The following is a description of a gene set: Thin nail Nail that appears thin when viewed on end. Human Gene Set: HP_THIN_NAIL studied in species Homo sapiens, and this is the list of marker genes: ALOXE3, RNU4-2, MBTPS2, TRPS1, IFT122, CAMK2B, HRAS, EZH2, EED, ANAPC1, SUZ12, RNU12, WNT10A, NSD1, ALOX12B, MSX1